Given this list of marker genes PLCB1, ST8SIA4, FBXO34, GRK3, CUTALP, HTRA4, TIA1, LIPT2-AS1, LINC01003, PRKAB2, HAPLN3, RBPMS, AMZ2, PSIP1, RNF185, DECR1, ARRDC3, JMY, SLC12A8, PIK3R3, SPIN1, PARN, NIPSNAP2, GPR65, SAMD9L, DAZAP2, MRPL30, KDELR1, CD47 (NCBI Gene Id 961), AFTPH, OARD1, AGA (aspartylglucosaminidase), SLC6A13, C12orf76, CHD3, CD46, FAM110B, RNPEP, ADD3, PITPNA-AS1, OIP5-AS1, ETS1, KRT25, LIX1L, SCARB2, PCCA, VAMP4, VPS4B, SRP9, ARL6IP5, CTBS, TMEM19, INTS8, RACGAP1, APAF1, CKAP2, GOLPH3L, MARCHF8, RNF103, STK19, POLI, SIAH1, TRMT5, GALC, ZFAND5, PHF6, ARHGAP15, PCBP2, TFDP2, MTARC2, SENP7, PLIN2, PHEX, SH3BGR, EBF2, ACSS1, MBNL3, CRYZL1, GDF11, ZC3H4, LGSN, ERCC5, PBX1, CYP39A1, GLIDR, KLHDC10, ZDBF2, ATRAID, MVB12B, NLRP2, FTO, PBXIP1, CFAP20DC, PDZD2, CTDSP2, SLC23A2, ZNF217, JAKMIP2, CAPRIN1, NDUFB5, EBF1, NT5E, CXCR2, TCF3, LPIN1, BRD3, RCAN3, PTPN13, MUC15, PPP1R12B, MDH1B, DYRK1A, PALS1, ABCG1, CCDC90B, BTN3A2, RTP4, ADNP, METTL21A, ZBTB26, SELL, TNFRSF11A, CDKN1C, BMPR2 (bone morphogenetic protein receptor type 2, NCBI Gene Id 659), TBC1D2B, LIPA, DDB2, FTX, STAG2, NEAT1, RSPRY1, TRERF1, DET1, RXFP2, GM2A, NLRC3, DENND4C, LRRC37A2, TCAIM, BCAR3, FUCA1, FAM167A, EVI2A, TPTE, NMT2, GTDC1, DNTTIP1, KDM5B, LAMC1 (NCBI Gene Id 3915), FBXO33, MAST4, PECAM1, DACT1, ZSCAN9, MAB21L2, PPP2R5A, LTA4H, TMEM185A, ZBED5-AS1 (ZBED5 antisense RNA 1), NPHP3, BRD8, CLCN3, H2AC11, PRKD1, PTER, SLC1A4, PLA2G4C (NCBI Gene Id 8605), PAM, PRUNE2, EIF3F, DCTN4, MEGF6, ZBTB3, STAM, GPSM2, RETREG1, ENSG00000289161, VPS37A, TTLL5, FRY, C14orf132, RCOR3, SLC25A46, STAT1, MARCHF6, PAN2, ETV7, MTSS1, VPS13B, SH3PXD2A, TINF2, SPTBN1, MBTD1, TP53INP2, RCBTB1, CDK5, YPEL5, here is a description of the gene set: It has been recently shown that N-ras plays a preferential role in immune cell development and function; specifically: N-ras, but not H-ras or K-ras, could be activated at and signal from the Golgi membrane of immune cells following a low level TCR stimulus. The goal of our studies was to test the hypothesis that N-ras and H-ras played distinct roles in immune cells at the level of the transcriptome. First, we showed via mRNA expression profiling that there were over four hundred genes that were uniquely differentially regulated either by N-ras or H-ras, which provided strong evidence in favor of the hypothesis that N-ras and H-ras have distinct functions in immune cells. We next characterized the genes that were differentially regulated by N-ras in T cells following a low-level TCR stimulus. Of the large pool of candidate genes that were differentially regulated by N-ras downstream of TCR ligation, four genes were verified in qRT-PCR-based validation experiments as being differentially regulated by N-ras (Dntt, Slc9a6, Chst1, and Lars2). Finally, although there was little overlap between individual genes that were regulated by N-ras in unstimulated thymocytes and stimulated CD4+ T-cells, there was a nearly complete correspondence between the signaling pathways that were regulated by N-ras in these two immune cell types. Since we were interested primarily in genes that were differentially regulated by N-ras following a low-level TCR stimulus, our microarray data comparison was between data from TCR-stimulated, WT CD4+ T-cells and from TCR-stimulated, N-ras KO CD4+ T-cells. Genes that were differentially regulated in the comparison between stimulated N-ras KO CD4+ T-cells and unstimulated N-ras KO CD4+ T-cells, as well as those genes that were differentially regulated in the comparison between stimulated WT CD4+ T-cells and unstimulated WT CD4+ T-cells were excluded from this analysis. To determine if N-ras and H-ras regulate different sets of genes in thymocytes, a comparison was made between the set of genes that were differentially regulated by N-ras in the vs. comparison and the set of genes that were differentially regulated by H-ras in the vs. comparison. from publication Lynch SJ, Zavadil J, Pellicer A (PMID 23755101) Genes down-regulated in CD4 T cells: NRAS knockout versus wildtype. species: Homo sapiens Human Gene Set: GSE45739_NRAS_KO_VS_WT_UNSTIM_CD4_TCELL_DN